Given this list of marker genes KMT2D, NHLRC1, MID1, HLA-DQB1, LRP12, LONP1, NTRK1, GBA1, ATP6V0A1, EPM2A, PDHA1, GIPC1, KDM6A, IGBP1, CRLF1, NFIX, HLA-DQA1, RILPL1, KAT6A, PIK3CD, NOS1, PIGN, CSPP1, KNSTRN, KIAA0586, SP110, NOTCH2NLC, ASAH1, SLC25A24, here is a description of the gene set: Increased susceptibility to aspiration pneumonia, defined as pneumonia due to breathing in foreign material, as manifested by a medical history of repeated episodes of aspiration pneumonia. Human Gene Set: HP_RECURRENT_ASPIRATION_PNEUMONIA studied in species Homo sapiens Recurrent aspiration pneumonia